Given this list of marker genes DBH, MEF2C, NPR1, PDCD4, TGFB2, PRKDC, CAV2, NAA35, NOTCH3, PPARG, PDGFD, NOS3, BMP4, MAP3K7, TPM1, GNA12, JUN, MIR27B, TENM4 (teneurin transmembrane protein 4), FGFR1, MIR137, MIR185, MIR362, APLN, IFNG, NF1, TCF7L2, MIR448, SIX1, NR4A3, PPARGC1A, MMP2, IL12A, ADAMTS1, SKP2, AIF1 (NCBI Gene Id 9471), MIR26A1, LDLRAP1, APOE, MIR214, MDM2, MIR199A1, GJA1, NOX1, MAPK11, NOTCH1, STAT1, MNAT1, PDE1A, PTGIR, FOXJ2, STAT3, HES5, MIR130A, TBX20, RGS5, NDRG2, GNAI2, CTNNB1, CDH13, PRKG1, ANG, MIR17HG, ABL1, TBX5, AKIRIN1, MIR499A, MIR34A, ID2, HTR1B, MIR200B, MIR548C, TGFB1, HDAC1, PRKAR1A, JAK2, WNT2, MEGF10, APOD, TNF, MIR20A, RGCC, PAXBP1, ITGA2, VGLL4 (NCBI Gene Id 9686), DNMT1, BMP10, ITGB3, HBEGF, OGN, TBX2, NKX2-5, RXRB, MIR1298, MIR590, RBPMS2, NDRG4, MIR17, AKT1, FES (NCBI Gene Id 2242), CNN1, MIR503, GATA6, NPY5R, IRAK4, RBP4, MIR133A1 (microRNA 133a-1), EDN1 (endothelin 1), CX3CL1, ELANE, XRCC5 (X-ray repair cross complementing 5), FOXP1, FGF9, RBM10, MIR4632, MIR140, FOXC2, CCN4, ANGPT1 (angiopoietin 1), SF1, PAK1, MSTN, SMAD1, NOG, MIR339, FGFR2, TERT (telomerase reverse transcriptase), MIR135B, MIR221, GSTP1, MIR96, PIM1, ACE2, RUNX1, ADIPOQ (adiponectin, C1Q and collagen domain containing), MIR143, CYBA, MMP9, MIR15A, MIR509-1, ERBB4, BMPR1A, ERN1, TAFA5 (TAFA chemokine like family member 5), PHB1, MIR27A, PIK3CA, RBPJ, BMP2, SAV1, IL6R, HMOX1, TLR4, CFLAR, PDGFB, DDR2, IL12B, HPGD, TGFBR1 (NCBI Gene Id 7046), MIR19B1, XBP1, TGFBR3, CTNNBIP1, CCN3, P2RY6, EPHB1, IGFBP5, KLF4, FOXC1 (forkhead box C1), GPER1, MIR873, MAP3K5, DIPK2A, SKI, ELN, PTEN, MIR638, MAPK14, IL10, CCL5, MFN2, IRAK1, IL18, CDKN1A, TP73, MIR208A, TRIB1, PRKCA, MIR204, BMPR2, NDC80, CDK1, ZFPM2, KCNK2, MIR223, GLI1, POLDIP2, MYH10, ANHX, CALCRL, TGFB3, MIR665, SELENON, MYOG, SERPINF2, IGFBP3, FGF20, CDKN1B, THBS1, MIR301A, S1PR1, SMPD3, NPPC (natriuretic peptide C), SIX5, MIR21, MYOCD, MIR146A (microRNA 146a), MYB, XRCC6, HGF, KPNA1, TACR1, SOD2, HEY2, NRG1, PDGFRB, EREG, FGF2, DSN1, TNFAIP3, EFEMP2, DDIT3, JARID2, ARID2, IL13 (NCBI Gene Id 96500), PIK3R1, SHH, MIR222, MIR145, IL6, MYD88, KRAS, FOS, YAP1, PPARD, MIR182, MIR199B, CCNB1, SUGT1, MIR424, MEF2D, IGF1, MIR1-1, here is a description of the gene set: species: Homo sapiens The expansion of a muscle cell population by cell division. Human Gene Set: GOBP_MUSCLE_CELL_PROLIFERATION